The following is a description of a gene set: Human Gene Set: GSE22886_UNSTIM_VS_IL15_STIM_NKCELL_UP Genes up-regulated in comparison of unstimulated NK cells versus those stimulated with IL15 at 16 h. from publication Abbas AR, Baldwin D, Ma Y, Ouyang W, Gurney A, Martin F, Fong S, van Lookeren Campagne M, Godowski P, Williams PM, Chan AC, Clark HF (PMID 15789058) species: Homo sapiens Immune cell-specific expression is one indication of the importance of a gene's role in the immune response. In order to identify such patterns, we set out to broadly profile gene expression in a variety of immune cells., and this is the list of marker genes: CMKLR1, ZBTB20, CLDN15, CYP24A1, SCAMP5, AKAP8L, ADA, PIP5K1B, BIRC2, SNRPN, BTD, CD6, ANGPT1 (NCBI Gene Id 284), SERPINC1, ACVR2A, WDR48, OXLD1, P2RX1, PAN2, C14orf93, GSDME, VPS11, HDAC5, BSDC1, GAREM1, FRAS1, ATM, TMEM242, HOXA5, ZNF33B, KRT84, LRRC37A3, SMARCD3, SEZ6L2, PDPK1, PCMTD2, TRIM10, ARHGEF17, WDR45, CDX4, KLRC4, RABGAP1, SNX29P2 (NCBI Gene Id 497262), FAM193B, SLC1A7, EAPP, CARF, RANBP17, STAT6, GPA33, APP, VPS8 (NCBI Gene Id 23355), DGLUCY, CLCN7, APOM, DPEP2, EFEMP2, OGA, BTN3A1, UBOX5, SPRR1B, HBQ1, IDUA, KDM4A, ADCY2, SEC31B, COL5A1, STAG3L4, CHMP1B, KLHL29, LAMA5, SNHG32, RXRB (retinoid X receptor beta), AMT, TLE1, ZBTB40, SELL, CCNL2, KAT6A, HSPBAP1, YPEL1, BAZ2A, COQ8A, PSPC1, ZNF767P, SIK3, LDB2, LMO1, TARBP1, BTG1, ADAM18, CAMK1D, CBFA2T2, ZNF394, IKBKE, SLC6A5, SRSF5, KNG1, LINC00115, EXOC3, PLCG2 (NCBI Gene Id 5336), GZMK, EZH1, CBX4, GPR153, ZDHHC17, PAIP2B (NCBI Gene Id 57218), GNS, ZNF556, MAU2, RIMS1, FAM174B, PAOX, EFHC2 (NCBI Gene Id 80258), ATG2A, PBXIP1, BTN3A3, ABLIM1, CCNG2, BCKDHA, TRANK1 (tetratricopeptide repeat and ankyrin repeat containing 1), HAP1, PDCD4, CPVL, UBTD1, PNISR (PNN interacting serine and arginine rich protein), MMP2, DDX28, ZCCHC14, KDM3A, ZNF212, ZBP1, MAP3K3, NME8, PRKY, FLT3, PARP4, SEMA5A, CBLIF, SPOCK2, PARP8, CITED2, NKTR, CLIC3 (chloride intracellular channel 3), CNNM3, PCDHGA8, CLEC2D, TEX41, CLK1, AMOT, PIK3IP1, GABPB1-IT1, TGFB2, LINC00390, MKRN1, CDKN2D, NCOA1, ZFC3H1, ATG14, VPS37A, PPP1CC, ZNF226, HCN2, NIPSNAP1, ATP12A, INSRR, RAP1GAP, UBA7 (ubiquitin like modifier activating enzyme 7), ROGDI, MCOLN3, TNP2, VILL, LRRC17, ELAPOR1 (NCBI Gene Id 57535), SLC17A7, NR1I3, SLC24A1, ZFHX4, HYI, BBS1, PAGE4, LGALSL, SPSB3, SYNM, CCT8L2, DCN, MFSD11, RBP4, GPRASP3, BICRA, ATP2B4, NLRP1, IRF3, IGKV1D-13, KLHL3, SFI1